Given this list of marker genes BCL2L1, PTPN11 (protein tyrosine phosphatase non-receptor type 11), FLT3, GRB2, CDKN1A (NCBI Gene Id 1026), NOX4, GAB2, STAT5B, STAT5A, PIM1, here is a description of the gene set: Reactome Pathway: STAT5 activation downstream of FLT3 ITD mutants part of: Signaling by FLT3 ITD and TKD mutants studied in species Homo sapiens STAT5 signaling appears to be preferentially activated downstream of FLT3 ITD mutants relative to the wild-type or FLT3 TKD mutants, although this is subject to some debate. STAT5 activation contributes to oncogenesis by promoting the transcription of a number of factors involved in regulating cell cycle progression, proliferation and apoptosis, among others.